The following is a description of a gene set: Human Gene Set: GOBP_REGULATION_OF_DENDRITIC_CELL_DIFFERENTIATION Any process that modulates the frequency, rate or extent of dendritic cell differentiation. species: Homo sapiens, and this is the list of marker genes: LGALS1, AGER, LGALS9, CEBPB, LGALS3, HLA-G, TMEM176B, HMGB1, LILRB1, FCGR2B, ZBTB46, TMEM176A, MIR223, HLA-B, CLEC12A, LILRB2